Given this list of marker genes BRAF, MAP1A (microtubule associated protein 1A), ATP8B1, NCMAP, RB1, OTP, TSC22D4, GPRASP3, FBXO45, SLC9A6, ETV5, VAX2, TSPO, DVL3, ADGRB1, POU3F1, CPEB3, DLL1, CNTNAP1, SNW1, APLP2, NPTX1, FRS2, LHX2, ERBB4, NOTCH1, SUN2, SLC38A8, CAMK2G (calcium/calmodulin dependent protein kinase II gamma), RPGR, SHANK3, MYT1L, RGS2, SKIL, MIR210, ITM2C, IRX2, RNF10, CYB5D2, FGF16, ARHGAP35, IQSEC1, EFNB2, PER2, PCP4, GIT1, GRXCR2, WNT8A, SYT4, JAK2, DCLK1, BARHL2, TBCD, PCSK9, BMERB1, HEXB, TDP2, CPNE6, NEPRO, NUMBL, RTN4R, ANK3, PPT1, FLRT1, HAND2, OBSL1, KIT, HCN1, RRAS2 (RAS related 2), STAT3, APOA4, NCS1 (NCBI Gene Id 23413), P2RX4, HEY2, PQBP1, BHLHE40, ENC1, GSX1 (NCBI Gene Id 219409), LRRK2, LHFPL5, TFAP2C, VANGL2, ZSWIM6, DDX6, PRAG1, DDR1, ADCY10, KRAS, SEMA4G, SOCS7, PTN, TMEM106B, DTNB, BAX, TREM2, STMN1, UST, PAK3, EIF4E, PLEKHG4B, ORC3, MYRF, TUBGCP2, MIR511, RUNX3, IRX1, SRF, RAB10, RTN4RL2 (reticulon 4 receptor like 2), PRX, TMC1, ERCC2, GPRC5B, UFL1, DLX2, CYFIP2, SEMA4C, CD2AP, NRP2, MYLIP, MARK1, SLC1A3, PTK2, ROBO4, LEMD2, GAK, DGUOK, TRIM32, PLA2G10, DBNDD2, KLF15, APCDD1, HOXC8, KCNA1, LLPH, KLK6, GATA2, IFNG, B4GAT1, CDKN2C, LIN28A, CERS6, NLGN2, LRRC7, NAP1L2, RTN4IP1, BHLHE23, HIPK1, GSK3B, NPC1, STAP1 (NCBI Gene Id 26228), CSK, NSMF, NUMB, PPP1R12C (NCBI Gene Id 79164), ZFHX2, THOC2, EPHB2 (EPH receptor B2), TBC1D24, TBX20, PLEC, TRIP11, NEDD4, DICER1, CTNNA1, COL6A1, CDK5R2, TAFA1, HAP1, SOX3, POTEJ, TTC8, TCF12, LTK, ABI2, CRKL, FAT3, TENM2, BCCIP, MIR221, EPHA2, MTOR, FGF21, HECW1, VCL, LAMB1, GFI1, MKS1, LBX1, SKOR2, LDLR, FAT4 (FAT atypical cadherin 4), STMN4, PTBP1, WDR62, LHX4, FOXN4, KIF20B, FGF14, NRP1, CAPRIN2, EYA1, NYAP2, MYOC, FOXO6, PAX2 (paired box 2), ADORA2A (adenosine A2a receptor), WNT5B, CRMP1, IL6, SLITRK5, NKX2-1, NELL2, CDKN1C, TBC1D23, EIF2B2, CHRNA3, VASP, NKX6-3, ACTL8, UQCRQ, ARX, ATAT1, WNT7B, ATF4, ABL1, CLN5, MTR, EPOP, BCL11A, KIF1A, NHLH2, NR2F1, GBA2, CTF1, TLR4, ANKRD1, NTNG1, GRM5, KIFBP, DLL4, ID1, RFX6, NTNG2, CTNND2, CNTN6, XRCC2, P2RY1, LIG4, MIR181B1, GABRB2, KAT5, NDRG4, TGFBR1, MYCL, GIGYF2, PLPPR5, OPRM1, CCDC39, VXN, LZTS1, DSCAM, TUBB2B (NCBI Gene Id 347733), TLX3, TNFRSF12A, FYN, IRX6, OLFM3, AGTPBP1, MARK2, HMGB1, SYN1, F2, HES6, KIAA1755, DNAJB11, NF1, MIR200C, IGF2BP1, PAK6, OGDH, MTMR2, NIN, PHOX2B, MCOLN3, MANF, PTPRS, NAP1L1, SCN1B, SEMA3D, FZD10, NFIB, CAMSAP1 (NCBI Gene Id 55490), ID4, SOX4, RIMS1, WASL, RTN4RL1, TNFRSF21, KIF5B, ADCYAP1, VPS13B, EIF4G1, SPEN (spen family transcriptional repressor), EIF2AK4, NCDN, DBX1, SOX6, STX1B, NSUN5, SPAG6, PRKG1, NECTIN1, DAGLA, IL1RAPL1, NCK1, SEPTIN4, SPG21, EGR2, TIAM2, DVL1, SPP1, TMEM108, ELP3, PTK2B, MYOT, CCL3, DPYSL5, CASP3, GPC2, FGF1, ABT1, WNT10B, NEXMIF, SMARCA1, ITGA1, PRKN, GRIP1, CDK5, FGF2, DSCAML1, INPP5F, TAL1, MFRP, C14orf28, MESP1, SLC1A1, IDH2, PPP1R12B, CSPG4, AKNA, RHOA, FZD3, HERC2 (HECT and RLD domain containing E3 ubiquitin protein ligase 2), LHX5, CBFA2T2, CCL11, HES1, GNRH1, GCM1, NOVA2, PPP2R5B (NCBI Gene Id 5526), MATN2, TCTN1 (NCBI Gene Id 79600), IFT20, NEGR1, HES2, CHRNA7, CDNF, CUX1, PRKCZ, PROM1, FGF20, TUNAR, LRP8, NDUFS2, LAMA2, ABL2, EP300, IFT140, NEURL1, HIPK2, NDP, XK (X-linked Kx blood group antigen, Kell and VPS13A binding protein), FKRP, DNM2, TLX2, MFSD2A, SNAPIN, EGFR, ARMCX5-GPRASP2, TTL, CNTN5 (contactin 5), SOX12, KCNQ1, OTX2, MOV10, SAMD11, GRIN2A, MACF1, MBOAT1, TMEM30A, GABRB3, ADCY6, CAMK2B, PPP1R12A, PHOX2A, SOX10, SERPINF1, COBL, TULP1, NCAM2, DKK1, FARP1, CELSR3, CEP120, NOTCH3, PTPN9, VEGFA, RORA, CEND1, ECE1, DUOXA1, NAV3, FOXG1, DHFR, BTBD1 (BTB domain containing 1), CERS5, VEGFC, UPF3B, FEV, BHLHE22, SLC12A5, ULK2, MTPN, GLDN, DLG5 (NCBI Gene Id 9231), PEX7, DCX, EPHA10, NTRK2, RAB21, LRP6, ZNF804A, YWHAZ, DCDC2, EFNA3 (NCBI Gene Id 1944), SATB2, RAP1A (RAP1A, member of RAS oncogene family), WNT4, ABI3, C5AR1, UGT8, SZT2, RSPO2, PITX2, CNR1, LGR6, EVL, NKX6-1, FIGNL2, LONRF2 (LON peptidase N-terminal domain and ring finger 2), SOX5, PLS1, THRB, SEMA4B, CLASP2, BDNF, NKX6-2, MCF2, ERCC6, EIF2B4, PPP3CA, RAB37, EDNRA, GPC1, FGF17, GDF11, CAMK1D, CDK6, APOD, TENM3, NCKIPSD, EDN2, TGFB1, GDPD5, ARHGEF2 (NCBI Gene Id 9181), SOD1, KALRN, ATF5, ACSL3, SOX9, NPY, SRRT, SPAG9, TRIO, USH2A, TRIOBP, P3H1, MYO6, BCL6, YAP1, FIG4, TNXB, NEO1, RYK, VIM, DRAXIN, BRINP3, VAX1, EDN3, PAK4, NR2F2, GPRIN3, SLC4A10, YTHDF2, COL3A1, ZDHHC17, CRB2, PRKD1, INHBA, CAMSAP3, DHX36, EPHA7, CCDC88A, PROX1, BMP2, RAF1, TBX6, OLFM1, SIPA1L1, HMG20B, FZD7, WDPCP, DRD3, SORL1, ATG16L1 (autophagy related 16 like 1), APOE, SYT17, JAG2, DBNL, SECISBP2, TRPC6, PPP1CC, HES7, SLITRK3, MEF2A, IST1, NRTN, VWC2L, HIF1A, MFSD8 (NCBI Gene Id 256471), RPGRIP1L, NTRK1, PTPRB, ZIC3, TRIM46 (NCBI Gene Id 80128), KCNJ10, HOXC10, MDM2, MMD, BLOC1S3, ILK, EFNB3, LYN, ZHX2 (zinc fingers and homeoboxes 2), FOXD1, SSNA1, SEMA6A, EPHA4, CX3CR1, PRICKLE1, EPG5, MAPK6, HEY1, CRK, CD3E, SH3GL3, SEMA6D, CCK, ZNF536, RARA, CASZ1, HOXD3, ARHGAP33, NPTN, WASHC5, ZMIZ1, SCARB2, B4GALT6, RAB6A, HOXD10, STK11 (serine/threonine kinase 11), DUSP15 (NCBI Gene Id 83747), ID3, HOXB3, NEUROG1, ACTBL2, PLK5, BLOC1S5, HMGB2, CDK5RAP3, SHOX2, PTPRK, BRINP1, VPS13A, EOMES, RASAL1, STRC, ADNP, GDF7, ROM1, FEZF1, TMEM132E, CUL4B, CSMD3, NFASC (neurofascin), PTPRU, SOX13, NDE1, ROBO1, CLRN1, ADGRV1, ZC4H2, B2M, RRAS, SLIT1, ARTN, SNX3, PLEKHG4, TGIF2, NR2E1, VSX2, SERPINI1, SEMA5A, RTN1, ATP2B2, GDF5, SPAST, SHTN1, SYNGAP1, HOOK3, PAK2, LHX9, PGRMC1, SLC23A2, SAMD7, ITGB4, MYB, PRTG, DMRT3, CNTN2, CDK5RAP1, PARP6, DLX3, MAPK8IP3, S100A9 (S100 calcium binding protein A9), DIXDC1, IRX4, CBLN1, ALCAM, SMURF1, PTPRJ, AIFM1, NTRK3, MYO16, CIT, NIF3L1, SLC25A46, SCRIB, WNT6, SMAD1, S100A8, NRL, FGF9, PALS1, ONECUT1, ROBO3, HHIP, ABLIM1, ZNF296, NEDD4L, NR5A2, FAIM2, DIP2A, ELL3, NEUROG3, FMR1, RAC3, LHX1 (NCBI Gene Id 3975), DAGLB, CLMN, EIF2B5, ZDHHC15, TGM2, SMARCD3, FGFR1, TNR, MEIS1, PTPRH, NTF3, SLC8A3, NLGN1, AP5Z1, DDIT4, TECTA, AXL, ITSN2, EPHB6 (NCBI Gene Id 2051), NAV2, SIAH1, FXR1, S100B, DOCK7, KAT2B, MDK, RETREG3, BEND6, WNT5A, FGF6, EMX1, CDK16, SOX21, LRP2, PCM1, NBN, ITPKA, CLSTN3, TSKU, ARF4, SUN1, TP73, TTC21B, KIFC2, NKD1, STAU2, CTDSP1, IL34, DENND5A, RP1L1, EIF2B3, JUN, SMO (smoothened, frizzled class receptor), XRN2, MICALL1, KHDC3L, FERD3L, FGF18, EDN1, SNAP25, MAP2K2, SCRT1, GPR157 (NCBI Gene Id 80045), SOD2, HDAC5, NEUROG2, WNT2B (Wnt family member 2B), OPHN1, WNT8B, DRD2, SOX14, RNF220, POU4F3 (POU class 4 homeobox 3), CNTNAP2, USP9X, NRG3, ADRA2C, RITA1, BMP5 (bone morphogenetic protein 5), SLITRK2, CEBPB, DMRTA2, ANKS1A, AVIL, TGFB2, FGFR2, SOX1, FRYL, ETV6, ACTL6B, APPL2, FPR2, FGF22, CC2D1A, CDON, LTA, SCLT1, GPR17, SEMA3C, PHGDH, SLC39A12, C3, TAOK2, AMIGO3, DNMT3A, SEC24B (SEC24 homolog B, COPII coat complex component), MGARP, PBX1, CRB1, DMD, CHD5, MARCKS, GNAT1, MIR219A1, FN1, CPNE1, LSM1, ACAP3, INS, RAB29, MED12, SIRT2, S1PR1, IGSF10, MAP1B, NCAM1, MINK1, KREMEN1 (NCBI Gene Id 83999), RAB6B, BTG2, LARGE1, DGKG, FA2H, MME, PDZD7, GSTP1, PRKCH, PRDM13, UGDH, ARK2C, ABCC8, ANXA2, PCARE, RGMA, SLC7A5, CCL2, DLL3, DNAAF4, LAMB2, RERE, GAS6, SLITRK1, TPRN, SOX8, ATOH7, EIF4ENIF1, OR10A4, FEZ1, TTC36, FBXO38, FILIP1, RORB, MAP6, SLC44A4, EMB, NEUROD6, SDC2, POMGNT2, CYFIP1, WDR1, ERBB2, PRDM1, PEX5, ANAPC2, CSPG5, FBXO7, KIRREL3, WEE1, MBOAT7, ADGRF1, IQGAP1, NCKAP1L (NCK associated protein 1 like), EPB41L3, VAPA, DHFRP1, MAP1S, FOXB1 (forkhead box B1), TOP2B, GHRL, RET, BMPR1B, YWHAE, PRDM6, NRXN3, UNC5D (unc-5 netrin receptor D), LHX3, NRCAM, TUBB2A, LIMK1, NANOS1, HSP90AA1, NAB1, GPR37L1, USH1G, PLXNB3, SH3TC2, ADAM17, PRDM8, DOCK10, GPR37, B3GNT2, ALKAL2, LPAR1, TOR1A, VCAN, CPNE5, SDCCAG8, EFNA1, SHANK1, FZD1, WNT2, SF3A2, BOK, MIR142, PREX2, NTN5, DYNLT1, WASF3, GBA1, SEMA4D, EZH2 (enhancer of zeste 2 polycomb repressive complex 2 subunit), FGF8, HRAS, ASTN1, QKI, PRUNE1, BMP7, TEAD3, FBXO41 (F-box protein 41), FGF23, NOS1, NKX2-5, METTL14, FRMD7, RASGRF1, NPHP4, PTK7, CHODL, ARHGEF28, WNT16, ZNF488, CTNNB1, FKBP8, BARHL1, NEUROD2, OPALIN, CCKAR, STYXL1, ROCK1, DRGX, GORASP1, PRMT1, FOXA1, GRB2, IL6ST, RTN3, PRKCA, POU3F2, ITSN1, VWC2, IFRD1, FZD9, THAP11, TRPC4, CRPPA, ALKAL1, NR4A2, HMG20A, AGER, PAX7, ALK, PLXNA1, SIX4, LDB1, NTN1, CLN8, P2RY12, EN2, DAG1, WNT9B, TRPC5, CDK1, MYH10, ECT2, PITPNA, ALKBH1, FZD8, C9orf72, UBB, FEZ2, DIP2B, CCDC85C, FGF19, SCYL1, NIPBL, EIF2B1, PHACTR1, SGK1, ISL2, PRDM12, KLK8, AREG, PUM2, GFRA3, TBR1, IRX3, NTN4, NAGLU, MINAR1, SIX3, NUP133 (NCBI Gene Id 55746), PTCH1, CDC27, UGCG, EEF2K, OLIG3, EMX2, CHN1, MIR125A, CD9, STX3, FZD2, SEMA7A (NCBI Gene Id 8482), STRAP, DLG4, IGSF9, RNF7, TIAM1, POTEE, WNK1, CARM1, RAP2A, KIAA0319L, SEMA6B, TUBB3, TOX (thymocyte selection associated high mobility group box), SEMA6C, PTPRG, UNC13A, HES3, INSM2, GPRIN1, BMPR2, MXRA8, C1QL1, NFIA, EPHB1, TH, GAREM2, GATA3, DZANK1, SUZ12 (NCBI Gene Id 23512), PALLD, LIF, ATP8A2, RND1, EPHA6, PIN1, PBX4, SEMA3G, GLI2, NGEF, AKT2, BNIP2, TPBG, PPP1R9B, MIR26A1, PTPRD, L1CAM, ZNF365, THY1, HEXA, APP, RBPJ, DCC, SMARCE1, HDGFL3, BCL7A, FUOM, ST8SIA2, CNTN1, C1QA (complement C1q A chain), SEZ6, KIF5A, TENM4, DIO3, NBL1, PAFAH1B1, ALS2, CNTN4, PRMT5, MIR125B1, SRGAP2C, PPP3CB, EPHB3, RUNX1, RNF157, S100A6, GDF6, CX3CL1, POTEI, NDNF (NCBI Gene Id 79625), PPP2R3A, TNF, PIGT, TTLL1, FOLR1, FGF5, EPO, STK24, WASF2, KEL, EFNA5, ERCC3, RAP1GAP, CERS2, ZMYND8, LEF1, HS6ST1, SRCIN1, TLR2, SDK2, FGF13, MT3, BTBD3, CDHR1, APLP1, CACNG7, ZFYVE27, GRN, BLOC1S2 (biogenesis of lysosomal organelles complex 1 subunit 2), GRIN3A, EXT1, DLX5, NR3C1, TRAK1, FAM151B, IHH, ELAVL4, EHMT2, BCL2, CHRNB2, NKX2-8, ATP1B2, PMP22, TRAK2, USH1C, KATNB1, PFKFB3, ELMOD3, MIR222, RAB35, RNF6, FSCN2, EED (embryonic ectoderm development), CLCN2, SVBP, USP33, VSX1, FGF10, EPHA3 (EPH receptor A3), NEUROD1, GSX2, ADARB1, CEP85L, LGI1, MICALL2, TANC2, ASCL1, BECN1, NTF4, ATP7A, AMIGO1, EFHC2 (NCBI Gene Id 80258), NCOA1, PLXNB2, SPINT1, GOLGA4, RTN2, ENAH, MDGA2, DUSP10, EFNB1, SS18L1, FRY, TWF2, RPL24, ATCAY, LST1 (leukocyte specific transcript 1), DTX1, IGF1, SH3RF1, GBX2, BOC, ANKRD27, NRXN1, ACSL6, SCN11A, VRK1, RAPGEF1, SRSF1, LRP1, SYT14P1, TRPV2 (transient receptor potential cation channel subfamily V member 2), LRP12, ARHGAP44, CHAC1, KLHL1, CPNE9, ITGA6, KNDC1, SLC45A3, IL2, KIF26A, LRRC4C, PLPP3, ULK4, SIN3A, MAP4K4, ANOS1, ABCA2, FGF3, RAPH1, CRTAC1, ISL1, PAX6, YWHAG, POSTN, RP1, NEXN, BIN1, ETV1, MICOS10-NBL1, FOXP2 (NCBI Gene Id 93986), IFNGR1, WASF1, PDLIM5, CCR2, ATF1, FOXO3, PTPN11, NDEL1, DDR2, MIOS, NAV1, SPINK5, SHH, ZNF212, PICK1, CFLAR, TGIF1, AZU1, EVX1, RHO, TRIM11, RIT2, NEFL, GSK3A, ATXN1, LAMA1, EPHA5, SEPTIN14, BHLHA15, MYCN, PPFIA2, NEFH, FBXW8, CREB1, STXBP1, KCTD11, VPS54, SYT3, STRN, SIX1, DRD1, HDAC6, NTM, OTOGL, DVL2, IRX5, CTHRC1, OMG, EPHA8, TMEM98, SPOCK1, PSEN1, HDAC1, XBP1, CUX2, PTK6, FTSJ1, PRKCQ, CAMK2A, COPS2, PICALM, XRCC5, CDH4, WNT11, TRAPPC9, TNC, CUL7, VTN (NCBI Gene Id 7448), KCNB1, GPM6A, CDC42, TCF3, RNF112, FKBP4, MAL, ITGA4, HEYL, RAB8A, MAP2, NEUROD4, RHEB, SYT2, GNGT1, CCR4, SFRP1, CDH23, DAAM2, PLXNA3, ADGRG1 (NCBI Gene Id 9624), AGRN, UNK, MINAR2, ANKRD24, KIF5C, NGFR, AFG3L2, NR2F6 (NCBI Gene Id 2063), GPR173, MAP4, LEPR, EN1, CEP290, SLITRK6, SKI, WNT3A, BBS1, DPYSL3, DISC1, ROBO2, GRID2 (glutamate ionotropic receptor delta type subunit 2), E2F1, GBX1, SPART, BRSK2, APBB1, GPX4, ALDH1A2, SALL1, SEMA4F, EHD1, ANO1, BRINP2, HOXA2, UCN, KIAA0319, UNC5B, KANK1, DCHS1, GDNF, BTBD6, MET, LMX1B, CDK5R1, PLXNA4 (NCBI Gene Id 91584), SPTBN4, NPR2 (NCBI Gene Id 4882), FOS (Fos proto-oncogene, AP-1 transcription factor subunit), CSF1, CNP, CTNNA2, VEGFD, GFAP, ISLR2, GNAT2, GFRA1, AGBL4, TTBK1, PBX3, BCHE, ATXN10, CHL1, METTL3 (methyltransferase 3, N6-adenosine-methyltransferase complex catalytic subunit), STK25, UBE4B, MAP2K1, DNER, FSHR, GPRIN2, FZD5, VASH2 (NCBI Gene Id 79805), RAB13, KDM1A, BSG, MAGI2, RND2, TP53, ASCL2, NOTCH2, BTBD2 (NCBI Gene Id 55643), PRPH2, UNC5A, PLAA, BRSK1, SPG11, COL25A1, TTYH1, PENK, NR2E3, SFRP2, POC5, NGRN, DTNBP1, NF2, MYD88, PTPRZ1, LYPLA2, NLGN4X, SCYL3, SEMA3A, CLU, PLP1, PLA2G3, BBS10, MAPK3, TYRO3, SYT1, ACTG1, CCND1, IFT172, CECR2, TUBA1A, ONECUT2, EPM2A, RTCA, TBX2, CDH11, NDRG1, FUT9, KIDINS220, MDGA1, PTEN, SNPH, FSTL4, BAG5, DDX56, SMAD4, PARD6B (NCBI Gene Id 84612), SLC11A2, PTPN1, SLC6A4, DAB2IP, RDH13, IL1B, C12orf57, CSF1R (colony stimulating factor 1 receptor), HLTF, KAT8, SERPINE2, TNFRSF1B, OLIG1, FLOT1, MIR137, CAMK1, POU4F2, WNT10A, BTG4, SLIT3, LMO4, HERC1, B4GALT5, UNC5C, SMIM45, CTTN, PJVK, SDC4, APBB2, OMP, ESRP1, GRM7, PAQR3, ARHGAP4, GABRB1, ERBB3, PSD, CELSR1, RPGRIP1, MYO7A, PACSIN1, NHERF1, LHX6, KCNQ3, C21orf91 (chromosome 21 open reading frame 91), RPS6KA5, MAPT, GDI1, FLNA, GAP43, SETX, ZEB2, WNT9A, ASTN2, DCT, PEX13 (NCBI Gene Id 5194), ZNF609, SEMA3F, DAB2, SOX2, POU4F1, KIF21A, SOX15, SLITRK4, KLF7, MIR431, RGS14, SULT4A1, WNT1, ASPM (assembly factor for spindle microtubules), DOK5, BNIP3, ADRA2B, RELN, RELA, PRKCI, ULK1, SEMA3E, JAG1, ZDHHC16, OPCML, CRABP2, POTEF, MYO9A, CD38, CDKL3, WHRN, BHLHE41, OSTN, LPAR3, NDN, ADCY1, SRRM4, CHD7, BORCS7, CDH2 (cadherin 2), TPPP, NYAP1, NTN3, NLGN3, ACSL4, CALR, CFAP418, MAPKAPK5, NCK2, BMAL1, CFL1, MYPN, LEP, POTEKP, EFHD1, FOXA2, SEMA3B, BBS4, PTPRO, VCAM1, ARFGEF1, NFE2L2, SEMA4A, HDAC2, LMX1A, NRDC, FLRT3, ID2, CDKL5, GABRA5, IFT88, AP2A1, CNGB1, AURKA, EFNA4, ARHGEF25, GRXCR1, FES, SUFU, STMN3, MAPK8IP2, SOCS2, ARF6, GCM2, WDR47, SLIT2, TWIST1 (twist family bHLH transcription factor 1), PAK1, MIB1, FLRT2, LGI4, GPR183, NRROS, TBCE, TENM1, RTN4, HMCN2, ARC, MOSMO, ATP9A, DAB1, IFT27, FGF7, ARSG, NFE2L1, SLC4A7, HOXD9, BAIAP2, ATL1, TRAPPC4, EEF2, NREP, BMPR1A, CXCR4, SCRT2, BLOC1S4, MED1, ZEB1, CDC20, RIMS2, TCF4 (NCBI Gene Id 6925), SH3GL2, BMP6, LHX8, PTF1A, ADGRL3, TULP3, SLC30A1, NEU4, LNX2, IL15RA, NGF, GPER1, ACTB, DCLK2, FZD4, MYCBP2, ELP6, OLIG2, DISP3, CAPRIN1, HES5, NCKAP1, DYNC2H1, VLDLR, CLCF1, LAMC3, SOX11, PRRX1, WNT7A, FMC1, RARB, CXCL12, IER2, BLOC1S1, PTPRT, ITGB1, RAB3A, INPP5J, MIR146A, BMP4, MAG, NR4A3, ARL3, PREX1, TNIK, GLI3, ABI1, HOXD1, ROGDI (rogdi atypical leucine zipper), LZTS3, PCDHAC2, AUTS2, SDK1, TNN, PLPPR4, RAB11A, PPP3R1, RACGAP1, CIB1, PCDH12, MMP14, BICDL1, ADGRG6, WNT3, FEZF2, UHMK1, TAOK3, IMPACT, KCNIP2, MNX1, DIAPH3, MMD2, GAS7, BLOC1S6, ZNF335, SOS1, PBX2, LRP4, FGF12, ADGRB3, MUL1, PTPRF, SYNE2, NMNAT2, ROR1, TWF1, CSNK1D, SCYL2, PLAG1, AKT1, MIR133B, NRN1L, MEF2C, ITGA3, CABP4, ARSB (NCBI Gene Id 411), MMP2, FXR2, NRBP2 (NCBI Gene Id 340371), CUL5, MTCH1, MYEF2, SCARF1, RASSF10, CDK5RAP2, ARHGEF40, SARM1, NFATC4, KIFAP3, MIR181C, NOG, HPRT1, PARD3, CDH1, RAPGEF2, RAC1, INSM1, REST, HTRA2, MAPK1, NAPA, ABITRAM, ZNF521, NCSTN, GALR2 (NCBI Gene Id 8811), PLXNB1 (NCBI Gene Id 5364), LLGL1, BCL11B, EDNRB, ZFHX3, HECW2, PLXNC1, ACP4, KLF4, TSPAN2, SEMA5B, FGF4, MEGF8, IL33, UNCX, PLXND1, PPP1R9A (protein phosphatase 1 regulatory subunit 9A), MAN2A1, PDE6C, STMN2, CELSR2, ZPR1, FARP2, S100A10, NKX2-2, TRPV4, EFNA2, MAP7D2, FGF11, SAMD14, CHRM1, DLX1, MMP24, SPRY3, HELT (NCBI Gene Id 391723), LRIG2, PTPRM, CAMSAP2, SRGAP2, PPIA, NOTO, TRIM67, ATOH1, UCHL1, ARHGEF10, AHI1, YTHDF1, HMGA2, NAB2, TAOK1, NRN1, PITX3, EML1, GPM6B, METRN, RAB17, YWHAH, CNTF, MAP3K13, RUNX2, RUFY3, NR1D1, GSDME, CLRN2, DBN1, MECP2, SHOC2, KIF13B, here is a description of the gene set: Generation of cells within the nervous system. Human Gene Set: GOBP_NEUROGENESIS studied in species Homo sapiens